Given this list of marker genes UST, FGD3, DNASE1L1 (NCBI Gene Id 1774), OARD1, PWWP2B, ADGRE2, PIK3AP1, HIVEP1, NAAA, ZNF479, ZNF703, SESN1, EML4, SNX18, CYREN, ARID5B, ZSCAN16, TMC8, VDR, LBH, AUNIP (NCBI Gene Id 79000), LONRF1, GSTA4 (glutathione S-transferase alpha 4), TNF, ADGRE1, SLC39A13, TNFRSF8, SNX9, VMO1, MYO19, ABHD3, ZFAND5 (zinc finger AN1-type containing 5), ZBTB14, RHOF, FAM110A, HTATSF1, RASA3, CTSC, TTC9, CDH23, CTSL, TES, PLAGL2, REST, UBFD1, PARP15 (poly(ADP-ribose) polymerase family member 15), PLVAP, TRAPPC4 (NCBI Gene Id 51399), PEX1, PHC1, ACTR3, GCH1, NOTCH4, RGL4, L1TD1, ING2, KPNA4, GOPC, MTOR, TCF7L2, DSTN, PRORSD1P, ARAP2, WDR11, CD7, SNX5, YPEL2, PGLYRP2, ANKMY2, SSBP4, PAG1, GPR137B, ZBTB18, ST3GAL5, HMOX1, RNF6, HSPA6, ST6GAL1, ELAVL4, SH2D3C, CCDC88C (coiled-coil domain containing 88C), DAPK1, IQCK, LRRC37B, PHF19, EOLA1-DT, CCDC34, LST1, DNAJA4, GUCY1B1, PER3, PDK4, FAM13A-AS1, SPRED1, TESMIN, TRAPPC2, R3HCC1L, MFSD12, C12orf57, GRPEL2, NFATC1, NDUFAF5, MGLL, CDYL2, SLAMF7 (NCBI Gene Id 57823), ITGB1, WASHC4, CAP1, TNFRSF1B (TNF receptor superfamily member 1B), MTSS1, STIM2, KLF11, SLC2A6 (solute carrier family 2 member 6), APOBEC3G, LPIN1, CUX1, ARHGEF12, ZBTB11, MS4A7, HERPUD2, FAM91A1, TTPAL, FIRRM, HES4, SEMA4C, RICTOR, CCSAP, XYLT1, GALNT10, MIS18BP1, PTP4A3, SMARCA5, CENPE, MXD3, HYCC1, ITGA4 (integrin subunit alpha 4), SAT1, IKZF5, JPH1, CCNE1, HES1, SNED1, ABI3, ARHGAP29, SLC25A12, SLC44A2, C3, SFTPD, ERMN, SMARCC1, ULK2, CEP78, FANCI, JAK1, SP140L, TBK1, RRAS, SMC6, PLRG1, VPS53, SHISA4, PPP1R17, KCTD9, TWF1, DEDD2, ASB2, TOP6BL, SLAIN2, UCKL1, TFRC, UBQLN1, NFKBIZ, INSIG1, CD47, RBFA, UBASH3B, RNF144B, SNAP23, PPP1R16A, PRR5, EFCAB11, TFDP2 (NCBI Gene Id 7029), WDR62, H2BC5, UBE2T (NCBI Gene Id 29089), EVL, TMEM63C, TUBGCP5, CD79B, KNDC1, ARHGAP17, PRIM1, HAPSTR2, ZRSR2, MYO18A, PRR5L, RNF149, here is a description of the gene set: Human Gene Set: GSE36888_UNTREATED_VS_IL2_TREATED_TCELL_2H_UP studied in species Homo sapiens Cytokine-activated STAT proteins dimerize and bind to high-affinity motifs, and N-terminal domain-mediated oligomerization of dimers allows tetramer formation and binding to low-affinity tandem motifs, but the functions of dimers versus tetramers are unknown. We generated Stat5a and Stat5b double knock-in (DKI) N-domain mutant mice that form dimers but not tetramers, identified cytokine-regulated genes whose expression required STAT5 tetramers, and defined consensus motifs for dimers versus tetramers. Whereas Stat5- deficient mice exhibited perinatal lethality, DKI mice were viable, indicating that STAT5 dimers were sufficient for survival. Nevertheless, STAT5 DKI mice had fewer CD4+CD25+ T cells, NK cells, and CD8+ T cells, with impaired cytokine-induced proliferation and homeostatic proliferation of CD8+ T cells. DKI CD8+ T cell proliferation following viral infection was diminished and DKI Treg cells did not efficiently control colitis. Thus, tetramerization of STAT5 is dispensable for survival but is critical for cytokine responses and normal immune function. from publication Lin JX, Li P, Liu D, Jin HT, He J, Ata Ur Rasheed M, Rochman Y, Wang L, Cui K, Liu C, Kelsall BL, Ahmed R, Leonard WJ (PMID 22520852) Genes up-regulated in T cells: control versus IL2 stimulation for 2h.